Given this list of marker genes CD151, FERMT1, KRT5, HLA-DQB1, SMARCAD1, KRT6B, FBXO28, KRT6A, DSG3, MMP1, COL7A1, LAMA3, ITGB4, KRT14, KRT1, DSG1, COL2A1, COL17A1, PLEC, KRT16, LAMB3, PKP1, HLA-DRB1, LAMC2, ITGA6, KRT17, here is a description of the gene set: Human Gene Set: HP_BLISTERING_BY_ANATOMICAL_LOCATION Blistering (presence of multiple fluid filled blisters) categorized according to the body site where they occur. Blistering by anatomical location species: Homo sapiens